The following is a description of a gene set: studied in species Homo sapiens The kneecap normally is located within the groove termed trochlea on the distal femur and can slide up and down in it. Patellar subluxation refers to an unstable kneecap that does not slide centrally within its groove, i.e., a partial dislocation of the patella. Human Gene Set: HP_PATELLAR_SUBLUXATION Patellar subluxation, and this is the list of marker genes: DNMT3A, COL12A1, FBN2, WNK3, USP9X, TBC1D7, YY1